The following is a description of a gene set: Mouse Gene Set: GOMF_PROSTANOID_RECEPTOR_ACTIVITY Combining with a prostanoid, any compound based on or derived from the prostanoate structure, to initiate a change in cell activity. species: Mus musculus, and this is the list of marker genes: Ptger4, Ptgdr, Tbxa2r, Ptger1, Slc22a22, Ptgdr2, Ptgfr, Ptgir, Ppard, Ptger3, Ptger2, Hpgd